Given this list of marker genes CYP3A43, CYP2W1, CYP4F11, CYP2S1, AMBP, CYP2U1, here is a description of the gene set: The chemical reactions and pathways involving a cytochrome. Human Gene Set: GOBP_CYTOCHROME_METABOLIC_PROCESS studied in species Homo sapiens